The following is a description of a gene set: studied in species Mus musculus from publication Motenko H, Neuhauser SB, O'Keefe M, Richardson JE (PMID 26092688) Mouse genes annotated to decreased tumor latency (MP:0010308) retrieved from the Mouse Genome Informatics database via MouseMine Mouse Gene Set: MP_DECREASED_TUMOR_LATENCY, and this is the list of marker genes: Rasal2, Tnfaip8l3, Atp6v0a2, Bub1b, Prf1, Ercc2, Nbn, Egr1, Trp53, Aldh2, Brca2 (NCBI Gene Id 12190), Klf10, Dclre1a, Bub1, Erbb2, Pcsk6, Foxo3, Eef1a1, Fbxw7, Mir203, Trim16, Ifng, Pard3, Il22ra2, Perp, Mcm3, Ranbp2, Lox